Given this list of marker genes CSF3R, AQP1, SDR16C5, DUSP6, MLPH, CD36, SELENBP1, RBPMS-AS1, SFTPA1, ESAM, FASN, C11orf96 (NCBI Gene Id 387763), CA2, BMP2, ZNF385B, RAB27A, FGG, CD44, GSTA4, LPCAT1, TIFA, SCD, MSMO1, SFTPD, FABP5, MED24, DRAM1, WIF1, ASRGL1, SOCS2, NFKBIA, ACSL4, B3GNT8, SFTPB, C1orf21, STC1, S100A14, PARM1, NNMT, KCNJ15, SMAGP, SPRY4, C3, C4BPA, CD74, ALPL, DBI, LRRK2, MFSD2A, RGS16, NPC2, MSN, CXCL3, CACNA2D2, LPL, CRTAC1, PPP1R1B, SFTPA2, LAMP3, PEBP4, ZDHHC3, AK1, CHIAP2, AREG, CSF3 (colony stimulating factor 3), FTL, HHIP, EDNRB, QDPR, CHI3L1, SLC6A14, MALL, SERPINA1, LTA4H (NCBI Gene Id 4048), HMOX1, RND1, PGC, PLIN2, ELAPOR2, SNX25, CHP1 (NCBI Gene Id 11261), CTSH, SLC34A2, KCNJ8, ALOX15B, ABCA3, PLA2G1B, CXCL2, CD83, SFTPC, ACADL, LRRC36, TPD52L1, BLVRB, SLC22A31, TMEM163, DCXR, PID1, CAT, LGMN, AKAP13, LANCL1-AS1, NECAB1, CHI3L2, SLC46A2, KMT2E-AS1, TMEM243 (transmembrane protein 243), C16orf89, TFPI, DMBT1, HSD17B4, ORM1, P3H2, TTN, CPB2, STEAP4, CHCHD7, LGALSL, SERPINB1, NRGN, MUC1, NAPSA, ETV5, ODC1, AGPAT2, HP, CDC42EP1, ETV1, FBP1, SOD2, GKN2 (gastrokine 2), FMO5, RASGRF1, SNX30, HHIP-AS1, HLA-DRB1, here is a description of the gene set: Human Gene Set: TRAVAGLINI_LUNG_ALVEOLAR_EPITHELIAL_TYPE_2_CELL species: Homo sapiens from publication Travaglini KJ, Nabhan AN, Penland L, Sinha R, Gillich A, Sit RV, Chang S, Conley SD, Mori Y, Seita J, Berry GJ, Shrager JB, Metzger RJ, Kuo CS, Neff N, Weissman IL, Quake SR, Krasnow MA (PMID 33208946)